Given this list of marker genes NISCH, ITGAX, DDB2, HLA-DQA1, DIAPH1, FAM53B, LMOD1, TRIM38, SIRPB1, ACP5, VPS52, MARS1, MAPRE2, LTA4H, BLNK, KCNJ9, CAMKK2, PIP4K2B, STX5, CLN3 (NCBI Gene Id 1201), ZBED1, ENTPD6, HLA-DMB, BABAM2, RPS6KB2, KDM4C, LMTK2, NEU1, UBN1, ASS1, TLR5, NMT2, FCN1, TRIM10, LPAR2, ABCC5, CD72, HTR2B, AKR1B1, TNFSF14, TCF25, PCCA, AP2A2, FGR, FUT7, FARSA, EEF1B2, CD83 (NCBI Gene Id 9308), DIDO1, NUTF2, ITPKB, AFG3L2, ADGRG6, ATF4, STX7, USP5, SF3B2, TRAPPC6A, TXNRD1, RPS6KA2, RPL12, ZG16, ALDH3A2, SERPINB6, PRKCA (NCBI Gene Id 5578), ADCY3, VENTX, FXR2, MAN2B2, EEA1, IFITM1, PLCG2, BANF1, MEF2C, BCAR3, MED24, ITGA3, GGA3 (golgi associated, gamma adaptin ear containing, ARF binding protein 3), PUF60, CCL19, STK10, VAV1, ADO, LIPA, DNAH7, ARHGAP25 (Rho GTPase activating protein 25), RASSF2, CD37, CYP27A1 (NCBI Gene Id 1593), DAXX, ERF, BLVRB, TNFRSF4, PPBPP2, MISP, TBC1D9B (TBC1 domain family member 9B), VAMP2, CTTN, DAP, FIG4, HTR7P1, IRF5, SMPD1 (NCBI Gene Id 6609), CYB5R1, DUSP3, MBTPS1, FMO4, CCRL2, HEXA, AKR1A1, FUCA1, TARBP1, CDC25B, CA4, USP24, SEC61B, HLA-DMA, TPD52L2, NOS2, NDRG2, BLTP2, NTNG1, ST14, ALDH1B1, JUP, IFFO1, SHMT2, LILRA2, PCDHA12, GLB1, GNB5, NUP188, EIF4A1, DHX38, FBL, PYGB, ZP2, PRCP, GNB1, KIF3C, VGLL4, CRABP2, PIM1, RAB32, TBC1D2B, TADA3, PI4K2A, PCK2, EEF1D (eukaryotic translation elongation factor 1 delta), IL1R1, TRAF3, PXDC1, FCGRT, RPL10A, ETFDH, ZNF263 (NCBI Gene Id 10127), UBA7, YARS1, CDA, MAGEB2, SREBF2, KIAA0930, ORC4, ECHS1, SUN2, TXLNA, PC, PIK3R3, CD151, TMEM184B, RASSF1, GAB1, PISD, SND1, PLEKHM2, SPRR2D, GPC3, COPS6, PMPCA, TEAD1, PFKFB1, VAT1, GPR39, ISG20L2, ATP6V0A1, ACRV1, GFUS, ITGB5, PATZ1, SIAH1, COMMD4 (NCBI Gene Id 54939), MLF2, LST1, GSTM5, GARS1, FAM131A, AOAH, PCDHB11, MFN2, here is a description of the gene set: from publication Chaussabel D, Semnani RT, McDowell MA, Sacks D, Sher A, Nutman TB (PMID 12663451) Human Gene Set: GSE360_HIGH_DOSE_B_MALAYI_VS_M_TUBERCULOSIS_MAC_UP studied in species Homo sapiens Genes up-regulated in comparison of macrophages exposed to 50 worms/well B. malayi versus macrophages exposed to M. tuberculosis. Monocyte-derived dendritic cells (DC) and macrophages (MΦ) generated in vitro from the same individual blood donors were exposed to five different pathogens, and gene expression profiles were assessed by microarray analysis. Responses to Mycobacterium tuberculosis and to phylogenetically distinct protozoan (Leishmania major, L. donovani, Toxoplasma gondii) and helminth (Brugia malayi) parasites were examined, each of which produces chronic infections in humans yet vary considerably in the nature of the immune responses they trigger.